The following is a description of a gene set: Mouse Gene Set: GOMF_G_PROTEIN_COUPLED_RECEPTOR_BINDING Binding to a G protein-coupled receptor. studied in species Mus musculus, and this is the list of marker genes: Ptger1, Ror2, Edn1, Ace, Gcg (glucagon), Tac4, Cav2, Ccl24, Arrb1, Creb3, Defb3, Gnal, C1qbp, Defb11, Wnt6, Chrm3, Dnajc14, Gip, Tmed2, Cxcl16, Nppa, Defb34, Tulp3, Usp33, Pde4d, Uts2b, Homer1, Penk, Jak1, Defb47, Calm3, Qrfp, Arhgef11, Ccl19-ps1, Mrap, App, Pomc, Calcb, Nms, Gnai3 (G protein subunit alpha i3), Cxcl15, Gna14, Ndp, Magi3, Sdcbp, Bicd1, Ccl17, Pyy, Nmu, Npff, Hspa1b, Ccl21b, Ccl19, Pth, Uchl1, Gna13, Wnt11, Ppp1r1b, Rpgrip1l (Rpgrip1-like), Rtp2, Ccl6, S1pr1, Sag, Defb40, Marco, Gnao1, Ccl25, Nsf, Ucn, Dnm1, Wnt10a, Ccl12, Xcl1, Fcgr1, Cxcl5, Ppp2ca, Gnas, Defb38 (NCBI Gene Id 360212), Ccl19-ps5, Gnai2, Ccl1, Npy, Grin2b, Sfrp1, Rala, Itch, Rtp4, Ccl21f, P2ry1, Tff2, Cxcl11, Agtr1a, Fcnb, Ptch1, Cklf, Tafa5, Agrp, Clic6, Defb2, Flna, Ccl21e, Ghrh, Fzd1, Wnt5a, Defb7, Arrdc3, Gprasp2, Gpha2, Adrb3, Pacrg, Gna11, Mrap2, Ccl19-ps3 (NCBI Gene Id 65959), Hspa8, Ccl9, Stat1, Oxt, Wnt1, Snx5, Gnat1, Wnt4, Magi2, Wnt16, Ptch2, Defb14, Fzd7, Ccl19-ps4, Ccdc88c, Wnt9b, Crh (corticotropin releasing hormone), Phb1, Fyn, Bbs1, Gnat3, Ccl20, Drd3, Ppp1r9b, Adcyap1, Adora2a, Ccl21a, Wnt2, Nes, Znrf3, Arhgef1, Dvl3, Tsnax, Stat3, Gnai1, Defb4, Ccl21d, Palm (paralemmin), Nherf1, Ppbp, Nmb, Gria1, Atp2a2, Ccl22, Ccl4, Edn3, Gnaz, Pmch, Adra2a, Gnat2, Rspo3, Insl3, Fem1al, Cxcl10, Ppy, Tac2, Wnt8b, Ednrb, Pdyn, Ccrl2, Psap, Cxcl9, Npb, Wnt5b, Cxcl13, Prnp, Saa2, Usp20, P2ry2, Ccl28, Tyk2 (NCBI Gene Id 54721), Cnih4, Defb1, Pnoc, Stub1, Defb6, Avp, Dnaja1, Ccl27a (NCBI Gene Id 65955), Shank3, Itgb4, Rln3, Cx3cr1, Wls, Pf4, Bambi, Edn2, Lrp6, Ucn2, Defb33, Ccl8, Kiss1, Dvl1, Wnt2b, Agtr1b, Zbtb16, Htr5b, Npw, Defb46, Tub (NCBI Gene Id 22141), Shank1, Prlh, Cnrip1, Dvl2, Grk3, Adrb1, S100a14, Avpr1a, Defb8, Myoc, Cxcl3, Gopc, Pick1, Gphb5, Adra2c, Atp1a3, Defb48, Tac1, Msmp, Jak2, Esr1, Defb15, Nars1, Reep1, Homer2, Ccl11, Grk2, Cxcl12, Defb10, S1pr2, Rapgef2, Arrb2, Arr3, Prkn, Calm1, Nup85 (NCBI Gene Id 445007), Akap5, Arhgef12, Defb9, Cxcl2, Usp4 (ubiquitin specific peptidase 4 (proto-oncogene)), Defb39, Il2, Cthrc1, Ghrl, Hba-a1, Ryk, Apln, Gm6040, Npffr2, Dnm3, Defb5, Adm, Gna15, a, Wnt9a, C3, Wnt3a, Vps35, Ucn3, Cckbr, Hspa1a, Cort, Prkar2a, Pdcd6ip, Wnt8a, Bdkrb2, Prok1, Hba-a2, Wnt10b, Psmc5, Ccl26, Cxcl14, Spx, Ccr2, Defb37, Vip, Cabp1, Calm2, Nedd4, Ccl27b, Gal, Wnt3 (wingless-type MMTV integration site family, member 3), Calca (NCBI Gene Id 12641), Aplp1, Agt, Grm5, Myh9, Ccl27al, Ccl2, Sh3gl1, Wnt7b, Gnaq, Ccl5, Insl5, Drd1 (NCBI Gene Id 77537), Gpr15lg, Rtp1, Rnf43, Nts, Adrb2, Dlg4, Wnt7a, Apela, Cxcl1, Prok2, Cxcl17, Necab2, Ccl19-ps6, Ccl7, Hcrt, Arap1, Rspo1, Fpr1, Adora1, Saa1, Fem1a, Rtp3, Ptpn11, Ccl3, Gna12, Homer3 (NCBI Gene Id 26558), Cx3cl1, Dnm2, Reep2